Given this list of marker genes Cpa1, Spi1, Tle5, Hcls1, Zg16, Prr13, Ctrl, Cfl1, Try4, Rnase1, Limd2, Klf13, Atf3, Prss2, Csf2ra, Dnttip2, Pnliprp1, Cotl1, Rpl13, Cela3b, Try5, Abi3, Ubxn1, Yipf3, Clps, Rgl2, Calm2, Prss3b, Cpb1, Gtf2b, Ctrb1, Cela1, Ppp1r18, Ptpn1, Arrb2, Ppy, Sycn, Bsg, Gnb1 (guanine nucleotide binding protein (G protein), beta 1), Snrpc, Rpl13a, Ptms, Pa2g4, Cela2a, Nupr1, Reg1, Jund, here is a description of the gene set: studied in species Mus musculus from publication Tabula Muris Consortium (PMID 32669714) Mouse Gene Set: TABULA_MURIS_SENIS_PANCREAS_LEUKOCYTE_AGEING